Given this list of marker genes Arf1, Carmil1, Gmfg, Washc4, Washc5, Ctnna2, Wasf2, Wasf1, Brk1, Dnai3, Wmp, Washc3, Nckap1, Carmil3, Carmil2 (capping protein regulator and myosin 1 linker 2), Washc2, Pick1, Coro1b (coronin, actin binding protein 1B), Rnh1, Abi2, Wasf3, Gm28729, Gmfb, Hip1r, Fchsd2, Cyfip1, Arfip1, Washc1, Arfip2, Ap1ar, here is a description of the gene set: Mouse Gene Set: GOBP_REGULATION_OF_ARP2_3_COMPLEX_MEDIATED_ACTIN_NUCLEATION Any process that modulates the frequency, rate or extent of actin nucleation mediated by the Arp2/3 complex and interacting proteins. species: Mus musculus